Given this list of marker genes Myo9a, Myh9 (NCBI Gene Id 97972), Rac3, Hck, Cotl1, Carmil1, Fyn, Mical1, Diaph2, Dyrk1a, Pof1b, Nckap1, Actg1, Arpc2, Myo1b, Pls1, Pdlim2, Myo18b, Src, Dnaja3, Aif1l, Gck, Lima1, Vps11, Ptges3, Actn1, Pdlim1, Actr3, Tek, Vps16, Pdlim3, Pls3, Pdlim4, Vps18, Cd2ap, Actc1, Gjb6 (NCBI Gene Id 52881), Myo1f, Twf2, Abi2, Coro1a, Ezr, Rac1, Keap1, Map3k1, Wipf1, Sh2b2, Dlc1, Lcp1, Dbnl, Rac2 (NCBI Gene Id 19354), Dusp22, Akap13, Mark2, Rhoq, Inpp5d, Coro1b, Dmtn, Gng12, Tmsb15b2, Actbl2, Acta1, Tmod1, Acte1, Cttn, Tsc1, Diaph1, Ackr2, Dapk3, Actb, Specc1l, Fmn1 (formin 1), Tmod3, Misp, Luzp1, Palld, Afap1, Amot, Cobl, Twf1, Mical2, Yes1, Cald1, Kptn, Pak1, Gas7, Fmn2, Myo6, Tpm3-rs7, Anxa1, Lmod1, Specc1, Aif1, Diaph3, Pdlim7, Hcls1, Myo1a, Espn, Tpm4, Dpysl3, Jam3 (NCBI Gene Id 97553), Vcl, Ldb3, Was, Shroom4, Myo5a, Myo3a, Pawr, Myo1c, Lmod2, Gas2l1, Tmsb15l, Tfpt, Tpm3, Fhdc1, Gdpd2, Myo9b, Avil, Tpm1, Prickle4, Apc2, Flna, Arpc3, Gas2l2, Dbn1, Pdlim5, Whrn, Tpm2 (NCBI Gene Id 22004), Bloc1s6, here is a description of the gene set: A filamentous structure formed of a two-stranded helical polymer of the protein actin and associated proteins. Actin filaments are a major component of the contractile apparatus of skeletal muscle and the microfilaments of the cytoskeleton of eukaryotic cells. The filaments, comprising polymerized globular actin molecules, appear as flexible structures with a diameter of 5-9 nm. They are organized into a variety of linear bundles, two-dimensional networks, and three dimensional gels. In the cytoskeleton they are most highly concentrated in the cortex of the cell just beneath the plasma membrane. Mouse Gene Set: GOCC_ACTIN_FILAMENT species: Mus musculus